Given this list of marker genes Grap2, Plekho1 (NCBI Gene Id 67220), Spsb3, Clasp2, Ly6a, Vps13d, Cers5, Kif1b, Ebpl, Lsm4, Tyk2, Pin1 (NCBI Gene Id 67670), Brd8, here is a description of the gene set: from publication Cui A, Huang T, Li S, Ma A, Pérez JL, Sander C, Keskin DB, Wu CJ, Fraenkel E, Hacohen N (PMID 38057668) Mouse Gene Set: CUI_LANGERHANS_TRAIL_RESPONSE_UP Genes positively differentially expressed in cell type: Langerhans upon treatment with cytokine: TRAIL in mouse lymph nodes in vivo. studied in species Mus musculus Cytokines mediate cell-cell communication in the immune system and represent important therapeutic targets. A myriad of studies have highlighted their central role in immune function, yet we lack a global view of the cellular responses of each immune cell type to each cytokine. To address this gap, the authors created the Immune Dictionary, a compendium of single-cell transcriptomic profiles of more than 17 immune cell types in response to each of 86 cytokines (>1,400 cytokine-cell type combinations) in mouse lymph nodes in vivo. A cytokine-centric view of the dictionary revealed that most cytokines induce highly cell-type-specific responses. For example, the inflammatory cytokine interleukin-1β induces distinct gene programmes in almost every cell type. A cell-type-centric view of the dictionary identified more than 66 cytokine-driven cellular polarization states across immune cell types, including previously uncharacterized states such as an interleukin-18-induced polyfunctional natural killer cell state.